The following is a description of a gene set: Human Gene Set: HP_SUBGLOTTIC_STENOSIS Subglottic stenosis studied in species Homo sapiens, and this is the list of marker genes: HLA-DPA1, GRIP1, SF3B4, EFL1, SNIP1, MAP3K7, HLA-DPB1, FREM2, NIN, TONSL, PTPN22, FRAS1, AFF4, CENPE, LTBP3, ROBO1, SMAD2, CTLA4, SOX9, FLNA, PRTN3, TBX3 (T-box transcription factor 3)